Given this list of marker genes SIX6, SPATA7, ZFX, ARL6IP6 (ADP ribosylation factor like GTPase 6 interacting protein 6), SF3B1, P3H2, YAP1, COL9A2, CRPPA, HLA-A, FAS, DUX4, SMCHD1, IMPG2, ADAMTSL4, EFEMP1, VCAN, POMT1, LRP5, GZF1, TUBGCP6, POMK, LAMB2, PAX6, DYRK1A, IPO8, COL4A1, IKBKG, PLOD1, LARGE1 (LARGE xylosyl- and glucuronyltransferase 1), B4GAT1, DNMT3B, FRG1, IQSEC2, DAG1, NSMCE2, COL11A2, CHRDL1, PRPH2, CTNNB1, CFI, RPE65, RXYLT1, LRAT, RAI1, IGFBP7, TRPM3, SETD2, P4HA2, CFH, HMX1, VHL, KIF11, RS1, CCND1, PRDM5, POMGNT2, MAF (MAF bZIP transcription factor), B3GALNT2, GNA11, COL11A1, FZD4, FKRP, ZNF408, AKT1, CHST14, ZNF469, IMPG1, LRP2, CYSLTR2, BEST1, FLII, CBS, COL9A1, POMGNT1, TSPAN12, XRCC4, NRCAM, ADAMTSL1, DUX4L1, NHS, PAK2, GNAQ, CACNA1F, LOXL3 (lysyl oxidase like 3), DEAF1 (DEAF1 transcription factor), TENM3, FBN1, FZD5, CAPN5, TUB, COL18A1, ATOH7, BAP1 (NCBI Gene Id 8314), ALDH1A3, PAX2, LCA5, PTPN22, POMT2, COL2A1 (NCBI Gene Id 444981), NDP, PTEN, GMPPB, KCNJ13, BCOR, TRAPPC2, COL9A3, ALG12, XYLT2, BMP4, DSE (NCBI Gene Id 29940), FKTN, ESAM, FOXE3, here is a description of the gene set: Human Gene Set: HP_RETINAL_DETACHMENT studied in species Homo sapiens Separation of the inner layers of the retina (neural retina) from the pigment epithelium. Retinal detachment